The following is a description of a gene set: Deubiquitination Human Gene Set: REACTOME_DEUBIQUITINATION studied in species Homo sapiens, and this is the list of marker genes: CDC20, TNFAIP3, PSMB2, USP30, ACTR8, H2AC25, USP11, RNF146, SMAD7, RNF123, OTUD7B, RNF128, OTUB1, SEM1, H2BC3, TRIM25 (NCBI Gene Id 7706), ESR1, ACTL6A, HGS, PSMD8, PRKN, USP17L28, SMURF2, H2AC13, USP25, PSMA7, USP21, USP17L30, USP17L1, H2BC1, RHOA, UFD1, TNKS2, CYLD, PSMD11, H2AC14, RHOT1, H2AC16, ABRAXAS2, TRAF6, PSMC4, OTUD3, H2BC15, CDK1, MYC, USP16, PSMA1, H2AC19, H2BC18, ACTR5, RUVBL1, STAMBPL1, TRAF2, CFTR, JOSD2, USP9X, PSMC5, PSMD7, PSMD2, USP17L2, JOSD1, BECN1, OTUD5, PSMB1, CDC25A, USP17L13, MBD6, NFKBIA, NEDD8, H2BC26, MUL1, USP4, USP17L11 (NCBI Gene Id 128966626), USP17L5, KEAP1 (NCBI Gene Id 9817), VCPIP1, VDAC3, USP17L8, USP17L17, MDM4, H2BC14, TAB1, BABAM2, NFRKB, INO80C, NOD1, RIGI, USP7, USP17L20, USP26, AXIN2, SKP2, PSMC6, PTRH2, AXIN1, USP2, MDM2, TNIP2, PSMD3, H2AC8, ABRAXAS1, BIRC2, STAM, SMAD4, CLSPN, PSMC3, ZRANB1, BRCC3, ADRM1, UIMC1, PSMB7, TAF9B, H2AC4, H2BC9, SNX3, H2AC12, TOMM20, PSMD14, USP17L27, IDE, ACTB, KAT2B, USP17L22, TGFBR1, H2BC7, USP17L19, VDAC1, USP24, TADA3, PSMB3, PSMA5, UBC, FKBP8, UBE2D1, USP18, USP14, WDR20, USP17L3, GATA3, ARRB2, RIPK1, H2AC1, UCHL3, BABAM1, H2AC17, USP19, H2BC8, RCE1, DDB2 (NCBI Gene Id 1643), H2AC21, USP28, UCHL5, TADA2B, PSMD6, USP5, BAP1, BRCA1, RAD23A, SENP8, ATXN7, ADRB2, HIF1A, SIAH2, PTEN, H2AC11, USP10, MYSM1, APC, H2BC4, FOXK2, PSMB4, USP49, OGT, USP33, SMAD2, USP17L26, PSMB6, BARD1, INO80B, BIRC3, H2AC15, ATXN3L, MAT2B, PSMA3, STAMBP, USP37, H2BC13, TFPT, PSMA6, OTUD7A, VCP, PSMC1, INO80, H2BC10, TRIM4, PSMD12, USP17L21, INO80E, USP17L12, RPS27A, CCP110, H2BC17, H2BC6, PSMC2, RNF135, TRAF3, H2BC5, USP42, H2AC6, UBB, SUDS3, PSMD13, KAT2A, NOD2, YOD1, H2AC18, INO80D, USP8, USP3, YY1, MCRS1, H2AC20, ARRB1, ATXN3, SMAD1, ASXL2, H2AC7, USP22, USP17L10, IFIH1, TNIP3 (NCBI Gene Id 79931), CCNA1, TAF10, H2BC12, PSMD1, UBA52, TP53, PSMB5, FOXO4, TOMM70, HCFC1, TGFBR2, NLRP3, ASXL1, USP13, USP12, TGFB1, USP17L4, CCNA2, WDR48, USP17L24, STAM2, TRRAP, PSMA4 (NCBI Gene Id 5685), USP17L18 (ubiquitin specific peptidase 17 like family member 18), POLB, MAP3K7, VDAC2, IL33 (NCBI Gene Id 90865), PSMA2, UCHL1, IKBKG, USP48, FOXK1, USP15, OTUB2, USP17L25 (ubiquitin specific peptidase 17 like family member 25), TNIP1, AR, USP34, KDM1B, USP47, H2BC11, RAD23B, SMAD3, TNKS, MBD5, USP20, EP300, USP44, USP17L29, RIPK2, H2BC21, MAVS, USP17L15